Given this list of marker genes NUDT2, OSBPL11, MANF, GPRC5C, CD244, GSTO1, CDX1, CDK7, MTARC1, CENPU, RAB4A, NTM, RASGRP3, ZC2HC1A, ZNF654, ACOX1, BTG1, ADGRE1 (NCBI Gene Id 2015), SERINC3, HLA-B, UBE2D3, TREM2, S100P (S100 calcium binding protein P), GSK3B, C21orf91, CEBPB, AAMDC, PDLIM5, KIAA0319, SPTBN1, BLTP3B, ANXA1, BEGAIN, SNRPB2, SCGB1D2, HSPB2, BHLHE40, ENPP2, ACVR1, MNT, GNAS, CDR2L, ATP10D, BRCA1, TNFAIP8, KRT81, NLRP3, DAZAP2, H3C2, H4C9, POLR2A, TM6SF1, MTARC2, SKP2, EDN3, RERE, FRS2, WWC2, TMEM59, NSD3, H3-3B, MRPL42, BCAR3, TTC21B, TFAP2B, SFXN1, SENP7, PIM1, CEACAM1, RRAGD, TM9SF2, PDE4DIP, TIGD6, CSF3, WASL, ADGRE2, AZIN1, SORD, UTP3, ANXA2P2, TMEM254, TMEM140, PAK5, TRPC4, FLNB, H1-0, STAT5B, CYB5R4, CAPRIN1, PIGH, CRTC3, SSBP2, ADGRD2, HS3ST1, CCR1, AVIL, CRBN, GLUL, ADAM10, ZRSR2P1, TXNRD1 (thioredoxin reductase 1), OXT, ESYT1, FAM124B, CHPT1, IMPACT, PMP22, CD40LG, TESPA1, NOP10, INTS12, HOXA4, CNOT7, SIAH2, SEC23B (NCBI Gene Id 980), TPPP, YWHAZ, POP4, NDUFV2, PITPNM3, SVIL, RAB6A, KCNB1, BCL2, EXT1, DNAJC7, RALYL, ZCWPW1, TREML2, ITPRID2, RFX4, TENM4, LRP5L, OSGIN2, BASP1, FAM30A, MIA, ZDHHC7, MYD88, MIA3, LYL1, HSD17B4, TRIP4, ACTR2, NCOA4, MAN2A2, SDCBP, MANBA, FBXL5, EID1, MCFD2, CTNNA2, PDCD4-AS1, DCN, MCL1, CACNG1, KLHL29, CSF1, RAB31, LSM3, RAB5IF, NDUFAF1 (NCBI Gene Id 51103), LY6G6C, AREG, PTP4A1, FNBP1L (formin binding protein 1 like), EREG, LYRM1, SRD5A1, ACAA1, BACH1, LRP12, MYL6, PTPN6, TRIM48, MXD1, PBXIP1, BACE2, SH3GLB1, NGDN, TPT1, RBKS, KCNH2, PCDHA10, PPP6C, C1RL, SLC2A10, SSR3, DHFRP3, LMOD1, FAM66D, GIT2, RUSC2, FLI1, KDM5B (NCBI Gene Id 10765), KIAA0513, NLK, GRB10, here is a description of the gene set: Human Gene Set: GSE3982_BASOPHIL_VS_NKCELL_UP from publication Jeffrey KL, Brummer T, Rolph MS, Liu SM, Callejas NA, Grumont RJ, Gillieron C, Mackay F, Grey S, Camps M, Rommel C, Gerondakis SD, Mackay CR (PMID 16474395) studied in species Homo sapiens Genes up-regulated in comparison of basophils versus NK cells. In the present study we used Affymetrix oligonucleotide microarrays to produce gene transcription profiles for the major leukocyte types in humans. This comprehensive dataset enabled us to not only establish which genes were expressed in each leukocyte type, but also which genes were expressed in each subset after activation. The used of a comprehensive dataset of gene profiles from all the major human leukocyte subsets enabled a novel and powerful means for identification of genes associated with single leukocyte subsets, or different immune paradigms.